The following is a description of a gene set: species: Homo sapiens Lack of symmetry between the left and right halves of the thorax. Asymmetry of the thorax Human Gene Set: HP_ASYMMETRY_OF_THE_THORAX, and this is the list of marker genes: RMRP, RNU4-2, AMER1, CDC42BPB, H19, IGF2, ANTXR1, MESD, AKT1, KCNQ1OT1, HERC1